The following is a description of a gene set: The process whose specific outcome is the progression of the glomerular endothelium over time, from its formation to the mature structure. The glomerular endothelium is an epithelial tissue that covers the internal surfaces of the glomerulus. Human Gene Set: GOBP_GLOMERULAR_ENDOTHELIUM_DEVELOPMENT species: Homo sapiens, and this is the list of marker genes: PECAM1, FOXC2, EDN1, EDNRA, CD34